Given this list of marker genes NR2F1-AS1, WDR11, ZNF770, ARMH4, NPAS3, TUBGCP5, RGMB, CWC27, NDUFS7, RPL12 (ribosomal protein L12), CFAP298, PCBP4, RPL5, ANKZF1, TEKT3, INTS2, NPAT, NUDT6, KCTD10, AHSA1, PPIA, FBXO24, DOC2A, LINC02851, S100A14, DLG4 (discs large MAGUK scaffold protein 4), PPP1R11, FDPS, CFAP298-TCP10L, FLAD1, IRAK1BP1, MDP1, SEC11A, LRP6, MIR4512, INO80B-WBP1, NUBP2, BZW2, DKC1, DLAT, RFC5, LINC03011, SART3, FIS1, AJUBA, PIPOX (NCBI Gene Id 51268), SINHCAF, ABCB8, ZNF133, MICOS10, VPS39-DT, GRPEL2, RPS25P3, VPS33B, CKMT2-AS1, MIA3, LRSAM1, SF3B6, RNU7-27P (RNA, U7 small nuclear 27 pseudogene), DYNLT4, GDPGP1, NIPSNAP2, SNORD58B, TMEM102, THAP10 (THAP domain containing 10), EME1, SETD9, MRPS17, TANK, IFTAP, MT-TE, COMMD6, PRRG2, ZNF200, TRIP4, EMSY, DRAIC, PHLDA1-DT, NOP10, ITGB3BP (integrin subunit beta 3 binding protein), HARS1, POLG, TIMM22, FAM149B1, MRPL16, TANK-AS1, ACY1 (aminoacylase 1), SNORD65 (NCBI Gene Id 692106), COPS5, ABHD14A-ACY1, FAM200B, SPSB3 (NCBI Gene Id 90864), NFRKB, RPL27, GFI1B, HAUS8, EPCIP-AS1, FBXL5, PIM1, UTP11, ZNF561-AS1, SMG7-AS1, C2orf49 (chromosome 2 open reading frame 49), ZFAS1, DDX49, NUDCD3, MAD2L1BP, CBR4-DT, PKP2, VTI1A, RNF145, MLEC, KPTN (NCBI Gene Id 96493), NME5, TNFAIP1, MRPS34, LINC01132, SH2B1, RTEL1-TNFRSF6B, METTL13, MIR3678, DARS1, VPS25, MRPS31, HNRNPA1P32, UCHL3, ENPP3, GOSR1, MICOS10-DT, VPS33B-DT, LRPPRC, DNMBP, WDR24, TEDC1, USP8, ZNF677, ATP8B1, GINS4, STAT6, DNMBP-AS1, GPATCH3, USP15, BZW1, LONP1 (lon peptidase 1, mitochondrial), SERF2, MT-TV, LIMA1 (LIM domain and actin binding 1), GSTCD, MPLKIP, ITFG2, ABHD14B, WASF2, COPS6, AHCTF1, ZWINT, MAD1L1, PSMF1, WDR6, ASB3, RPS27L, RPLP0, RNU6-215P, MIR17HG, JPX, SSBP1, ZNF692, VPS4B, INTS4, MT-TT, NDUFS3, CBR4, BORCS8-MEF2B, ID2-AS1, COA6-AS1, PABPN1, POLR3GP2, C17orf75, IFT56, HUS1 (HUS1 checkpoint clamp component), RAB2B, C5orf34 (chromosome 5 open reading frame 34), LSM8, MLH1, SCAMP5, ITFG2-AS1 (NCBI Gene Id 647957), RPS27, TBC1D19, DBNL, TOX4, FBXW11, LZTS2, BORCS8, ZBTB45, ZMAT2, USP30, ST7-OT4, GLUD1P3, DHX57, ZNF302, CHP1, OIP5, NAPA-AS1, PRKAR1A, METTL2B, COX16, NDUFA3, TMEM184A, RBM15, BCAS3, MFAP3, BUB1B, ERLIN2, RTTN (NCBI Gene Id 284278), SUPT5H, RNF139-DT, NXT2, MRPL46, HARS2, EME2 (essential meiotic structure-specific endonuclease subunit 2), RFX1, MRPS31P5, RC3H2, VPS51, ACADVL, MICOS10-NBL1, HUWE1, HAUS2, EEF1A1P23, GAS8, ZZZ3, NUF2 (NUF2 component of NDC80 kinetochore complex), ZDHHC6, TCERG1, BMS1P4, POP5, MT-ND6, RPL17-C18orf32, STX18, ANKFY1, NUTM1, PIH1D2, TARS2, NOSIP, ENTPD1-AS1, ZNF384, SECISBP2L, SNORA13, PER1, NKAPD1, EBNA1BP2, CS, CCT8, CCT2, PHF12, MRPL27, TOM1L2, H4C8, HOXC-AS2, TRUB2, PPP2R1A, AJUBA-DT, INO80B, TFPT, TATDN3, DMXL1, BRF2, ZNF397, NCAPD2, SEMA4B, SNORD12C, RACK1, CD164, TMA16, KIFBP, SNRPD1, RBIS, TMCO1, SYNCRIP, HEMK1, DRC3, MRPS11, DENR, DYNC2I1, OPA1, TRAV13-2, RTEL1, SPATA7, NDUFAF1, DTWD1, SRA1, ZSCAN29, RPL30P11, EXD1, HOXA-AS2, MT-TF, GTPBP3, MICAL3, HMGA2, SLC26A2, SNAPC5, ESYT1, UBOX5, ATM, SUGCT (succinyl-CoA:glutarate-CoA transferase), RGS5, DIAPH1-AS1, MIR3912, ARID1A, TTC4, ALG10B, DHFR2 (dihydrofolate reductase 2), PTCH1, FBXO22, ARID4A, NKAPP1, CATSPERD, SARNP, GATC (glutamyl-tRNA amidotransferase subunit C), ORMDL2, ENSG00000232995, STX18-AS1, LINC01012, NPM1P19, EMSY-DT (EMSY divergent transcript), ATAD3A, NPM1, RUVBL1, H4C16, ALDH3A2, RNF139, EIF2S1, LRRC57, AGBL3, RFXANK, ITSN1 (NCBI Gene Id 6453), RPL37, RPS6KB1, MGAT1, RNF34, TMEM248, IQCD, PPP1R12A, VPS13B-DT (VPS13B divergent transcript), KIF18A, DCAF6, COA6, JOSD2, ZNF561, DNAJC11, LRCH4, VPS13B (NCBI Gene Id 54990), ISY1-RAB43, EPS8, PRDX1 (peroxiredoxin 1), HMGN2, MRPL48, KRT18, AFG2A (NCBI Gene Id 170576), CSPP1, EEF1A1P32, MCFD2, LRRC49, SPNS1, IMPDH2, TMBIM4, COQ4, CEP70, ISY1, TPCN1, WDR11-DT, CCDC97, RNF6, ERCC1, DMAP1, ANO8, UBE3B, ZNF24, SLC12A9, DIAPH1, PAXBP1, ATF7IP, SF3A3, FAM98B, NUSAP1, SPINK13, LINC01932, NKTR, PCLAF, KBTBD4, RNU5A-1, STMN3, FAM227B, LINC00431, TRIM41, SAR1B, PHLDA1, RPS16, MRPS18C, STX16, PRPF31, GBA1, C2orf49-DT, TMEM242-DT, GCDH, KRT8, RGMB-AS1, KRR1, ANKHD1-DT, SNORD95, POLG-DT, SND1-DT, ZNFX1, INTS12, ST7-AS1, MED23, ATP13A4, RAD51AP1P1, COPE, MT-RNR1, C3orf52, MFSD14A, MCCC1, CYCSP10, GCHFR (GTP cyclohydrolase I feedback regulator), ZC3HC1, CFAP57, C12orf76, COX8A, BANP, BTBD19, PXK, CRYZL1 (NCBI Gene Id 9946), ADAP2, PISD, ZC3H10, KDM4C, ARPC4, BMS1P4-AGAP5, MTF2, SECISBP2, EFCAB7, NELFE, SMG7, TADA3 (NCBI Gene Id 10474), DHX30, GHDC, H2AZ2-DT, LETMD1, ZMPSTE24-DT (NCBI Gene Id 120017338), SLC35A3, RN7SL449P, SREK1IP1, SKIC2, RHEBL1, DMXL1-DT, ISCU, ASXL1, RAD21, SCP2, TTI2, PSMA3-AS1, RBM28, TASOR2, FASTKD5, SBDS, TIPIN, MRPL51, KLHL20, ZCCHC9, VPS39, PNPLA8, PDLIM1, TEFM, ACTL6A, THAP5, WARS2-AS1, PXN-AS1, NSUN3, PRPF18, MROH8 (NCBI Gene Id 149674), PTENP1, KHSRP, DDX1, SNRNP200, TRIAP1, PIH1D1, NSL1, TAFA2, RPS11, TMEM242, EPB41L4A-AS1, DCP1A, NLK, WEE2-AS1, H2AZ2, ANKHD1-EIF4EBP3, RPS7, TMED2 (NCBI Gene Id 10959), CCHCR1, HELQ (NCBI Gene Id 113510), INO80, UQCC6, ZMPSTE24, SIPA1L1, EPM2AIP1, MPC2, COL17A1, BCL6 (NCBI Gene Id 604), CTR9, CNPY2-AS1, MTND5P11, ID2, ZBTB40, ZNF592, CSTPP1, FAM114A2, PIP5K1B, MORN2, GALM, ERLEC1, KMT5A, SLC1A3, LENG1, BAZ1B, CDK5RAP1 (CDK5 regulatory subunit associated protein 1), RNU6-460P, ATP6V1D, LMAN2, MIR3913-1, FAM228B, MTERF1, C6orf226, VIPAS39, ZSCAN26 (zinc finger and SCAN domain containing 26), RPL17, NOXA1, ANKHD1, MRPL44, STX16-NPEPL1, HNRNPC (heterogeneous nuclear ribonucleoprotein C), FANCG, SMG8, BMS1, ZNF343, ADAP1, WDR62, RAB44, ATG9A, OSCAR (osteoclast associated Ig-like receptor), DARS1-AS1, EPS8L3, IFT20, MTCO3P12, LGALS8, DNAJB9, PTPN11, RPS6, METTL15, ACHE, ZNF446, WBP1, ZNF562, ANAPC5, DPM3, ZNF774, OSBP, MYO9B, NOP2 (NOP2 nucleolar protein), SP2, COASY, RPN2, MRPL3, TTC7A, ANKMY2, GOLGA5, EXD3, ZNF219, ARPC4-TTLL3 (ARPC4-TTLL3 readthrough), TXN2, NR5A2, NUP42, TUT1, CA13, NCOA4, EIF3F (NCBI Gene Id 8665), RPL29, LARS1, here is a description of the gene set: Genes containing one or more binding sites for (ZNF250) in their promoter regions (TSS -1000,+100 bp) as identified by GTRD version 20.06 ChIP-seq harmonization. Human Gene Set: ZNF250_TARGET_GENES studied in species Homo sapiens from publication Yevshin I, Sharipov R, Kolmykov S, Kondrakhin Y, Kolpakov F (PMID 30445619)